The following is a description of a gene set: Binds to and stops, prevents or reduces the activity of a serine/threonine protein phosphatase, an enzyme that catalyzes the reaction: protein serine/threonine phosphate + H2O = protein serine/threonine + phosphate. species: Homo sapiens Human Gene Set: GOMF_PROTEIN_SERINE_THREONINE_PHOSPHATASE_INHIBITOR_ACTIVITY, and this is the list of marker genes: PPP1R14A, PPP4R4, PPP1R14D, PABIR2, PPP1R14B, PPP1R1A, PABIR3, PPP1R8, PPP1R11, PPP1R2, PABIR1, TPRN, MYOZ1, PPP1R17, PPP1R14C (protein phosphatase 1 regulatory inhibitor subunit 14C)